The following is a description of a gene set: Reactome Pathway: Mitochondrial translation part of: Translation studied in species Homo sapiens Of the roughly 1000 human mitochondrial proteins only 13 proteins, all of them hydrophobic inner membrane proteins that are components of the oxidative phosphorylation apparatus, are encoded in the mitochondrial genome and translated by mitoribosomes at the matrix face of the inner membrane. The remainder, including all proteins of the mitochondrial translation system, are encoded in the nucleus and imported from the cytosol into the mitochondrion. Translation in the mitochondrion reflects both the bacterial origin of the organelle and subsequent divergent evolution during symbiosis. Human mitochondrial ribosomes have a low sedimentation coefficient of only 55S, but at 2.71 MDa they retain a similar mass to E. coli 70S particles. The 55S particles are protein-rich compared to both cytosolic ribosomes and eubacterial ribosomes. This is due to shorter mt-rRNAs, mitochondria-specific proteins, and numerous rearrangements in individual protein positions within the two ribosome subunits (inferred from bovine ribosomes in Sharma et al. 2003, Greber et al. 2014, Kaushal et al. 2014, reviewed in Agrawal and Sharma 2012).<br>Mitochondrial mRNAs have either no untranslated leader or short leaders of 1-3 nucleotides, with the exception of the 2 bicistronic transcripts, RNA7 and RNA14, which have overlapping orfs that encode ND4L/ND4 and ATP8/ATP6 respectively. Translation is believed to initiate with the mRNA binding the 28S subunit:MTIF3 (28S subunit:IF-3Mt, 28S subunit:IF2mt) complex together with MTIF2:GTP (IF-2Mt:GTP, IF2mt:GTP) at the matrix face of the inner membrane. MTIF3 can dissociate 55S particles in preparation for initiation, enhances formation of initiation complexes, and inhibits N-formylmethionine-tRNA (fMet-tRNA) binding to 28S subunits in the absence of mRNA. Binding of fMet-tRNA to the start codon of the mRNA results in a stable complex while absence of a start codon at the 5' end of the mRNA causes eventual dissociation of the mRNA from the 28S subunit. After recognition of a start codon, the 39S subunit then binds the stable complex, GTP is hydrolyzed, and the initiation factors MTIF3 and MTIF2:GDP dissociate.<br>Translation elongation then proceeds by cycles of aminoacyl-tRNAs binding, peptide bond formation, and displacement of deacylated tRNAs. In each cycle an aminoacyl-tRNA in a complex with TUFM:GTP (EF-Tu:GTP) binds at the A-site of the ribosome, GTP is hydrolyzed, and TUFM:GDP dissociates. The elongating polypeptide bonded to the tRNA at the P-site is transferred to the aminoacyl group at the A-site by peptide bond formation at the peptidyl transferase center, leaving a deacylated tRNA at the P-site and the elongating polypeptide attached to the tRNA at the A-site. The polypeptide is co-translationally inserted into the inner mitochondrial membrane via an interaction with OXA1L. After peptide bond formation, GFM1:GTP (EF-Gmt:GTP) then binds the ribosome complex, GTP is hydrolyzed, GFM1:GDP dissociates, and the ribosome translocates 3 nucleotides in the 3' direction along the mRNA, relocating the polypeptide-tRNA to the P-site and allowing another cycle to begin. TUFM:GDP is regenerated to TUFM:GTP by the guanine nucleotide exchange factor TSFM (EF-Ts, EF-TsMt).<br>Translation is terminated when MTRF1L:GTP (MTRF1a:GTP) recognizes an UAA or UAG termination codon at the A-site of the ribosome. GTP hydrolysis does not appear to be required. The tRNA-aminoacyl bond between the translated polypeptide and the final tRNA at the P-site is hydrolyzed by the 39S subunit, facilitating release of the polypeptide. MRRF (RRF) and GFM2:GTP (EF-G2mt:GTP) then act to release the remaining tRNA and mRNA from the ribosome and dissociate the 55S ribosome into 28S and 39S subunits.<br>Mutations have been identified in genes encoding mitochondrial ribosomal proteins and translation factors. These have been shown to be pathogenic, causing neurological and other diseases.<br>Translation can stall due to lack of tRNAs or due to defects in mRNAs and tRNAs. In the case of a defective tRNA, the 28S and 39S ribosomal subunits are separated and the MTRFR-MTRES1 complex binds the peptidyl-tRNA and the empty A-site of the ribosome, resulting in ejection and hydrolysis of the peptidyl-tRNA and regeneration of the tRNA and the 39S ribosomal subunit. In the case of a mRNA lacking a stop codon (non-stop mRNA), ICT1 recognizes the empty mRNA channel in the ribosome and causes ejection and hydrolysis of the peptidyl-tRNA., and this is the list of marker genes: MRPL10, MRPL14, MRPS14, MRPL43, MTIF2, GFM2, MRPS6, MRPL42, MT-TH, PTCD3, MRPS11, MRPL13, MT-TR, MT-ND5, OXA1L, MRPL17, MT-CYB, MT-TY (NCBI Gene Id 4579), MRPL2, MRPL4, GADD45GIP1, MRPL54, MT-TK, MT-TM, MT-ND4, MRPS22, MRPL1, MRPL38, MT-ND4L, MT-TI, MTRES1, MRPL27, MRPS26, MRPL15, MRPL11, MRPL50, MRPL16, MRPL47, MRPL32 (mitochondrial ribosomal protein L32), MT-RNR2, MTRF1, MRPL18, MT-TW, MRPS5, MRPL22, MRPL55, MRPL45, MRPS28, MIEF1, MT-TV, MT-CO2, MRPL34, MRPS31, MRPS10 (NCBI Gene Id 95834), MT-TF, MTRFR, MRPL19, MRPS23, MRPS27, MT-CO3, MRPL57, MRPL24, MRPS35, MT-TQ, TSFM, MRPS12, MT-ND2, MRPL52, TUFM, MRPL28, MT-TL2, MT-ND1, MRPS18A, MRPL40, MRPL12, MRPS2, MRPL41, MT-TS1, MRPS18B, MRPS7 (mitochondrial ribosomal protein S7), MT-RNR1, MT-TP, KGD4, MRPS18C, CHCHD1, MRPL51, MTIF3, MRPL46, MRPL23, MRPS24, MT-TL1, MT-ND3, AURKAIP1, MRPL33, MRPL37, MRPS17, MRPL39, MTRF1L, MT-TG, MT-CO1, DAP3, MRPL9, MRPL53 (NCBI Gene Id 116540), MALSU1, MT-TA, MRPL44, MRPL21, MRRF, MRPS25, GFM1, MRPL48, MRPS21, MRPS33, MRPL36, MRPS9, MTFMT, MRPS15, MRPL20, MRPS30, MT-TS2, MT-TC, MT-ND6, MRPL3, NDUFAB1, MT-ATP6, MT-TT, MRPL49, MRPL30, MRPL58, ERAL1, MRPS34, MT-ATP8, MT-TN, MRPS16, MT-TD, MT-TE, MRPL35